Given this list of marker genes CYP11B2, HSD11B2, KCNJ10, GATM, EHHADH, SEC61A1, SLC34A1, NDUFAF6, here is a description of the gene set: Human Gene Set: HP_RENAL_SODIUM_WASTING studied in species Homo sapiens An abnormally increased sodium concentration in the urine in the presence of hyponatremia. Renal sodium wasting